Given this list of marker genes Dync2i2, Klc3, Dynll1, Pcm1, Ift25, Ift80, Ift70a1, Ttc21b, Ift140, Ift27, Daw1, Ift22, Ssna1, Cep131, Nme7, Tub, Ift88, Lca5, Cluap1, Ift70a2, Dync2i1, Traf3ip1 (NCBI Gene Id 98598), Kif17, Dynlt2b, Ift70b, Arl3, Ift43, Bbs12, Wdr35, Wdr19, Lca5l, Ift172, Kif3b, Ift81, Cilk1, Bbs1, Intu, Ift74, Dync2h1, BC048507, Ift57, Ift122, Mak, Fuz, Wdpcp, Ift56 (intraflagellar transport 56), Rpgr, Ttc21a, Ssx2ip, Ift20, Ccdc38, Dync2li1, Ift52, Ift46, here is a description of the gene set: species: Mus musculus Mouse Gene Set: GOBP_INTRACILIARY_TRANSPORT The bidirectional movement of large protein complexes along microtubules within a cilium, mediated by motor proteins.